Given this list of marker genes Anln, Iqgap2, Iqgap1, Rtkn, Pdcd6ip, Racgap1, Ect2, Iqgap3, Plec, here is a description of the gene set: studied in species Mus musculus A process which results in the assembly, arrangement of constituent parts, or disassembly of an actomyosin contractile ring. Mouse Gene Set: GOBP_ACTOMYOSIN_CONTRACTILE_RING_ORGANIZATION